The following is a description of a gene set: Human Gene Set: KEGG_MEDICUS_REFERENCE_OKAZAKI_FRAGMENT_MATURATION studied in species Homo sapiens Okazaki fragment maturation. Pathway ID: N01472. Pathway type: Reference. Pathway class: nt06509 DNA replication. Pathway Definition from KEGG: POLD+PCNA -> DNA2 == RNaseH2 == FEN1 -> LIG1, and this is the list of marker genes: RNASEH2B, POLD1, DNA2, LIG1, POLD4, POLD3, FEN1, PCNA, RNASEH2A, RNASEH2C, POLD2